Given this list of marker genes Pdcd5-ps, St13, Pdcl, Bag5, Pdcd5, Pdcl3, here is a description of the gene set: studied in species Mus musculus Any process that stops, prevents or reduces the frequency, rate or extent of protein folding. Mouse Gene Set: GOBP_NEGATIVE_REGULATION_OF_PROTEIN_FOLDING